Given this list of marker genes SLC4A1, RHCE, PIEZO1, UMPS, RHD, SLC25A38, RHAG, HBB, SLC11A2 (solute carrier family 11 member 2), STEAP3, KCNN4, GLRX5, TRNT1, here is a description of the gene set: A qualitative impression that red blood cells have less color than normal when examined under a microscope, usually related to a reduced amount of hemoglobin in the red blood cells. Hypochromia Human Gene Set: HP_HYPOCHROMIA species: Homo sapiens